Given this list of marker genes F5, Ykt6, Tmed2, Serpina1b, Sec23a, Sec13 (NCBI Gene Id 67817), Lman2l, Lman1, Tbc1d20, Tfg, Trappc9, Gorasp1, Csnk1d, Sar1b, Sec23ip (Sec23 interacting protein), Napa, Napg, Ppp6r3, Sec24b, Nsf, Sec16b, Ctsz, Sec31a, Mcfd2, Scfd1, Trappc1, Stx5a (NCBI Gene Id 70340), Ppp6r1, Ctsc, Gria1, Tmed10, Sec22b, Trappc10, Rab1b, Ankrd28, Sec24d, Trappc2, Preb, Uso1, F8, Cnih1, Folr1, Sec22c, Trappc5, Trappc6b, Sec22a, Lman1l, Cnih2, Gosr2, Ppp6c, Sec24c, Sec24a, Tgfa, Areg, Serpina1c, Trappc2l, Trappc4, Sec16a, Trappc6a, Napb, Col7a1, Cnih3, Lman2, Golga2, Bet1, Cd59b, Sec31b, Rab1a, Trappc3, Stx17, here is a description of the gene set: Mouse Gene Set: REACTOME_COPII_MEDIATED_VESICLE_TRANSPORT studied in species Mus musculus COPII-mediated vesicle transport